The following is a description of a gene set: from publication Ji H, Ramsey MR, Hayes DN, Fan C, McNamara K, Kozlowski P, Torrice C, Wu MC, Shimamura T, Perera SA, Liang MC, Cai D, Naumov GN, Bao L, Contreras CM, Li D, Chen L, Krishnamurthy J, Koivunen J, Chirieac LR, Padera RF, Bronson RT, Lindeman NI, Christiani DC, Lin X, Shapiro GI, Jänne PA, Johnson BE, Meyerson M, Kwiatkowski DJ, Castrillon DH, Bardeesy N, Sharpless NE, Wong KK (PMID 17676035) Germline mutation in serine/threonine kinase 11 (STK11, also called LKB1) results in Peutz-Jeghers syndrome, characterized by intestinal hamartomas and increased incidence of epithelial cancers. Although uncommon in most sporadic cancers, inactivating somatic mutations of LKB1 have been reported in primary human lung adenocarcinomas and derivative cell lines. Here we used a somatically activatable mutant Kras-driven model of mouse lung cancer to compare the role of Lkb1 to other tumour suppressors in lung cancer. Although Kras mutation cooperated with loss of p53 or Ink4a/Arf (also known as Cdkn2a) in this system, the strongest cooperation was seen with homozygous inactivation of Lkb1. Lkb1-deficient tumours demonstrated shorter latency, an expanded histological spectrum (adeno-, squamous and large-cell carcinoma) and more frequent metastasis compared to tumours lacking p53 or Ink4a/Arf. Pulmonary tumorigenesis was also accelerated by hemizygous inactivation of Lkb1. Consistent with these findings, inactivation of LKB1 was found in 34% and 19% of 144 analysed human lung adenocarcinomas and squamous cell carcinomas, respectively. Expression profiling in human lung cancer cell lines and mouse lung tumours identified a variety of metastasis-promoting genes, such as NEDD9, VEGFC and CD24, as targets of LKB1 repression in lung cancer. These studies establish LKB1 as a critical barrier to pulmonary tumorigenesis, controlling initiation, differentiation and metastasis. Human Gene Set: JI_METASTASIS_REPRESSED_BY_STK11 species: Homo sapiens Adenocarcinoma metastatic program genes up-regulated in A549 and H2126 cells (lung cancer) lacking functional STK11 but down-regulated by the normal gene., and this is the list of marker genes: PON3, SIM2, SLC45A4, ITGB5, LGSN, DUSP4, FGB (NCBI Gene Id 2244), GLRX (NCBI Gene Id 90885), MAP7, CEACAM6 (CEA cell adhesion molecule 6), F2RL1, TENT2, NEDD9, ID4, CD24, NPTX1, LTBP1, CNTN1, EPAS1, MTUS1, TNS4, AREG, PBX1 (PBX homeobox 1), CYP1B1, BDKRB2, GDF15